Given this list of marker genes AKAP5, CAMTA1, MTOR, ACTN3, PLCG2, PPP3CC, CHERP, EFHB, MYOZ2, CIB1, ERBB3, PPP3R1, PRNP, TBC1D10C, FHL2, LACRT, ATP2B4, PTBP1 (NCBI Gene Id 63477), C10orf71, HOMER2, CLEC7A, NFAT5, SLC9A1, PPP3CB, PPP3R2, AKAP6, LMCD1, DYRK2, MYOZ1, HOMER3, SPPL3, RCAN1, CHP1, PPP3CA, MAPK7, SLC8A2, TNF, IGF1, GSK3B, CHP2, here is a description of the gene set: Human Gene Set: GOBP_REGULATION_OF_CALCINEURIN_MEDIATED_SIGNALING Any process that modulates the frequency, rate or extent of calcineurin-mediated signaling. studied in species Homo sapiens